The following is a description of a gene set: Human Gene Set: KEGG_MEDICUS_REFERENCE_EARLY_ENDOSOMAL_FUSION species: Homo sapiens Pathway Definition from KEGG: (RABGEF1+RABEP1) -> RAB5 -> (PIK3C3+PIK3R4) -> PI3P -> EEA1 Early endosomal fusion. Pathway ID: N01302. Pathway type: Reference. Pathway class: nt06125 Membrane trafficking (bacteria)., and this is the list of marker genes: EEA1, PIK3C3, RAB5B, RAB5C, RAB5A, RABEP1, RABGEF1, PIK3R4